Given this list of marker genes Gsk3b, Wdr1, Dlg5, Llgl1, Lhx2, Pdlim1, Pdcd6ip, Wnt11, Nherf1, Dst, Crb2, Nckap1l, Atn1, Arpc5, here is a description of the gene set: Mouse Gene Set: GOBP_MAINTENANCE_OF_CELL_POLARITY species: Mus musculus The maintenance of established anisotropic intracellular organization or cell growth patterns.